Given this list of marker genes PIEZO1, PIGM, JAK2, NOTCH1, SERPINC1, KCNN4, RECQL4, SLC4A1 (solute carrier family 4 member 1 (Diego blood group)), MET, KIF20A, CTNNB1, here is a description of the gene set: Human Gene Set: HP_ABNORMAL_PORTAL_VENOUS_SYSTEM_MORPHOLOGY Any structural anomaly of the portal venous system, which comprises all of the veins draining the abdominal part of the digestive tract, including the lower esophagus but excluding the lower anal canal. The portal vein conveys blood from viscera and ramifies like an artery at the liver, ending at the sinusoids. Tributaries of the portal vein, which make up the portal venous system, are the splenic, superior mesenteric, left gastric, right gastric, paraumbilical, and cystic veins. Abnormal portal venous system morphology studied in species Homo sapiens